Given this list of marker genes C3AR1, PRL, AIF1, TBC1D8, TNR, C3, IFNA21, COL8A1, FGF5, CR1, CFD, ITGB4, IL6, A2M, IFNA5, TLR4, C1S, IFNA16, ADAMTS20, here is a description of the gene set: Human Gene Set: LI_PBMC_MENOMUNE_A_C_Y_W_135_AGE_18_45YO_3DY_DN from publication Li S, Rouphael N, Duraisingham S, Romero-Steiner S, Presnell S, Davis C, Schmidt DS, Johnson SE, Milton A, Rajam G, Kasturi S, Carlone GM, Quinn C, Chaussabel D, Palucka AK, Mulligan MJ, Ahmed R, Stephens DS, Nakaya HI, Pulendran B (PMID 24336226) Many vaccines induce protective immunity via antibodies. Systems biology approaches have been used to determine signatures that can be used to predict vaccine-induced immunity in humans, but whether there is a 'universal signature' that can be used to predict antibody responses to any vaccine is unknown. Here we did systems analyses of immune responses to the polysaccharide and conjugate vaccines against meningococcus in healthy adults, in the broader context of published studies of vaccines against yellow fever virus and influenza virus. To achieve this, we did a large-scale network integration of publicly available human blood transcriptomes and systems-scale databases in specific biological contexts and deduced a set of transcription modules in blood. Those modules revealed distinct transcriptional signatures of antibody responses to different classes of vaccines, which provided key insights into primary viral, protein recall and anti-polysaccharide responses. Our results elucidate the early transcriptional programs that orchestrate vaccine immunity in humans and demonstrate the power of integrative network modeling. Genes down-regulated in peripheral blood mononuclear cell 3d vs 0d in adults (18-45) after exposure to Menomune A/C/Y/W-135, time point 3D species: Homo sapiens